Given this list of marker genes GRM7, GAD1, SV2A, ZNF148, PNPO, PIGS, GLS, SCN2A, GCSH, NEUROD2, GRIN1, GNAO1, ATP6V0A1, SIK1, STXBP1, UGDH, AKT3, ARX, ABAT, PRKAG2, CDK5, CYFIP2, PNKP, SLC25A22, PIGA, CAMSAP1, MTOR, PIGQ, SLC32A1, ATP1A2, KCNQ2, AMT, COQ4, PLPBP, ASNS, NSF, ALG11, CASK, ALG14, C1QBP, SLC25A46, KCNC2, FGF13 (fibroblast growth factor 13), VARS2, SCN1B, IER3IP1, DPM2, MOGS, CNPY3, PIGP, GNB1, KCNA1, ALDH7A1, PIK3CA, CDKL5, CUL3, DMXL2, BRAT1, TRIM8, DNM2, here is a description of the gene set: The burst suppression pattern in electroencephalography refers to a characteristic periodic pattern of low voltage (<10 microvolts) suppressed background and a relatively shorter pattern of higher amplitude slow, sharp, and spiking complexes. EEG with burst suppression studied in species Homo sapiens Human Gene Set: HP_EEG_WITH_BURST_SUPPRESSION